Given this list of marker genes DSP, JUP, RERE, HOXD13, SMO, BHLHA9, here is a description of the gene set: Webbing or fusion of the fingers, involving soft parts and including fusion of individual finger bones. studied in species Homo sapiens Osseous finger syndactyly Human Gene Set: HP_OSSEOUS_FINGER_SYNDACTYLY